The following is a description of a gene set: species: Homo sapiens Binding to a regulatory region composed of the transcription start site and binding sites for transcription factors of the RNA polymerase I transcription machinery. This site is often referred to as the CORE element. In mammalian cells, the CORE element functions in conjunction with the Upstream Control Element (UCE), while in fungi, protozoa, and plants, the CORE element functions without a UCE. Human Gene Set: GOMF_RNA_POLYMERASE_I_CORE_PROMOTER_SEQUENCE_SPECIFIC_DNA_BINDING, and this is the list of marker genes: BAZ2A, TAF1C, SMARCB1, SMARCA4, TAF1B, RRN3, UBTF, UBTFL6, TBP, UBTFL1